The following is a description of a gene set: The cellular developmental process involved in cell fate commitment that occurs after cell fate specification, in which a cell is irreversibly committed to a cellular developmental fate which is heritable on cell division. studied in species Mus musculus Mouse Gene Set: GOBP_CELL_FATE_DETERMINATION, and this is the list of marker genes: Prox1, Myod1, Prrx1, Ntf5, Mef2c, Lbx1, Ntf3, Barhl2, Gata2, Gata3, Ctnnb1, Isl1, Ptch2, Sox17, Notch2, Mesp1, Gata6, Nkx2-2, Chrdl1, Jag2, Nkx6-3, Ebf2 (early B cell factor 2), Dll3, Cdc42, Wnt7a, Hand1 (heart and neural crest derivatives expressed 1), Hes1, Pax6, Wnt1, Cyp26b1, Atoh1, Bmp4, Fezf2, Foxg1, Tbx2, Ptch1, Ascl1, Pax2, Smarca4, Hoxa2, Otx2